Given this list of marker genes BAIAP2, CDC42EP3, CCL11, ALOX15, BIN1, CARMIL2, BAIAP2L2, GRB2, VASP, RAC1, CDC42EP2, CTTN, NCKAP1L, DLG1, CDC42EP1, CDC42EP5, PRKCE, RICTOR, CCL24, NCKAP1, WASHC2C, PTK2B, NCK2, ARPC2, FCHSD1, CDC42EP4, CRACD, LMOD1, NCK1, MLST8, CCL26, LMOD2, ARF6, TENM1, C15orf62, PFN1, FCHSD2, KIRREL1, CSF3, FER, HCK, BAIAP2L1, CCR7, CCL21, EVL, NPHS1, PYCARD, BAG4, SNX9, PFN2, CARMIL1, MTOR, here is a description of the gene set: species: Homo sapiens Human Gene Set: GOBP_POSITIVE_REGULATION_OF_ACTIN_FILAMENT_POLYMERIZATION Any process that activates or increases the frequency, rate or extent of actin polymerization.